Given this list of marker genes GPR65, IL18, VNN1, SMAD3, CD72, ERBIN, CD7, TMEM126A, SHLD2, NFKB1, SCIMP, HAVCR1, LSM14A, CCL28, FCGR2B, ARID1B, MIR708, GAB2, NOS2, IL10, TRPV4, TP53BP1, CX3CR1, MAP3K7, KLK3, DLL1, HSPA1A, SLC19A1, CD2AP, ZDHHC4, ATAD5 (NCBI Gene Id 79915), MARK4, BRPF3, RBP4, PRKCZ, HTR2A, CNOT7, TRIM62, GPS2, C8B, CCL4, PARP1, LOX, CYP26B1 (cytochrome P450 family 26 subfamily B member 1), IGLC3, ZBTB17, GPR18, INPP5D, PTPN2, VAMP7, HLA-C, CLEC12A, ZBTB26, MIR181C, APOA1, CTLA4, YPEL4, PYHIN1, LYAR, TBK1, ILDR2, TBC1D10C, APP, POMC, CD81, LIPA, HK1, CST7, IGHM, IL27RA, PAK2, GATA1, LETMD1, FCGR2A, GGT2P, IL13, CDKN1A, GRN, SOCS1, SOS1, PRDX2, IGHA2, MCU, CRTAM, MIR486-1, NR1H4, RBM14, COLEC10, CCL25, SH3RF1, PTK2, SMPDL3A, RAET1G, PIK3CA, TASL, CD226, CSF1, PIK3R1, HSF1, HCK, GAL, TRIL, KCNJ8, CEP63, METTL3, TRIM5, VTCN1, CCL1, GPX1, TNFAIP8L2, PTPN11 (protein tyrosine phosphatase non-receptor type 11), H4C1, BGLAP (bone gamma-carboxyglutamate protein), DLG5, INAVA, WNK1, IFNK, SPHK2, NFAM1, CD244, HOXB8, ENTPD7, FES, LEP (leptin), DDRGK1, MAPK3, CD1E, PLCB1, MFHAS1, HEXIM1, RIN3, PLA2G2A, PLA2G2D, RPS19, LEO1, CD2, HLA-DRB5, VSIR, PYCARD, GKN2, ING5, XBP1, IL6, CEBPB, NPLOC4, MAPK9, MAD1L1, PLA2G7, HLA-A, KIR3DL3, IFNL4, ZBTB25, HLA-DOB, XG (Xg glycoprotein (Xg blood group)), FLT3LG, FGL1, LAT, SIT1, GPR137B, CD300LB, BLNK, LAMP2, STK39, MPL, EFNB3, LIMK1, PRXL2A, ABHD8, BCL6B, THBS1, MSN, WAS, TLR10, PLCL2, TACR1, GP6, SELENOS, IL1A, KIR2DL5A, IFIH1, POLR3D, MEFV, RUNX3, LILRA3, GPR171 (NCBI Gene Id 29909), ACTL6B, EVI2B, ADCY7, CD3D, IFNA2, PLA2G4A, NLRC5, ADORA1, NCKAP1L, MBL2, TRAF3IP3, NEDD9, PMS2, ZDHHC5, PBRM1, C2, GLMN, C1R, ZDHHC9, IL15RA, LILRA2, LAPTM5, ANO6, EVPL, SH3KBP1, SQSTM1, NLRC3, PF4, CD79A, IL1B (interleukin 1 beta), IL17D, LITAF, CD96, CFHR4, TNFSF18, CD28, SMARCA4, CCR7, RC3H2, FBXW7, ULBP1, HLA-DQA1, HMOX1, ATAT1, INHBA, FGF10, EIF2B5, TOB2, XIAP, PJA2, FYB2, C5AR2, IKZF3, TNFSF4, PCBP2, CBLB, HHLA2, NOD2, IGHA1 (NCBI Gene Id 3493), POLR3C (NCBI Gene Id 10623), IL12RB1, ADA, PARP9, OGT, C8A, CD3E, CSF1R, C6, PDE4B, EBI3, TRBC2, BTN3A1, SIRPA, KLRC2, SCIN, IL18R1, BTNL10P, TAL1, CASP6, IL34, UBE2N, BCL2, FYB1, RNF39, TLR6, ZP3, BTN1A1, SASH3, LST1, PCK1, LAIR1, MIR221, BRD7, EPHB2, GPR137, SOS2, RIPOR2, MR1, KMT5B, ORM1, ELP6, OXSR1, IRAK3, TRIM25 (NCBI Gene Id 7706), KAT6A, HOXA9, MNDA, BTK, ERMAP, ZAP70, CEACAM20, BTN2A2, ZBTB6, TNFRSF11A, KLF13, TNFSF8, NLRP1, TRIM27, ADORA2B, TAFA3, CLU, TCIM, NFKBIL1 (NFKB inhibitor like 1), BCL6, IL23R, LAMP1, MIR17, TESPA1, ACP5 (acid phosphatase 5, tartrate resistant), TMEM176B, BTN2A1, NLRP6, EXOSC3, IL2, OTUD5, ATG9A, ACIN1, SOD1, LAT2 (linker for activation of T cells family member 2), CARD10, BTN3A3, SHH, MEF2C, COLEC12, FGL2, IL4R, TRPM4, PKN1, SYK, SLC7A5, PTGER4, SERPINB9, PIK3R6, MYC, FGR, TGFB2, RNF41, BTN2A3P, CNOT4, CXCL17, EPX, HLA-DPB1, ITGAM, CD99L2, MED23, TLR5, WNT3A, APLF, HSPA9, ZNRF4, LATS2, IL23A, CD1A, FCGR3B (Fc gamma receptor IIIb), PHPT1, ZBTB2, FURIN, XCL1, RASAL3, MED1, RAB29, SLC15A3, FPR1, SELENOK, MICA, RSAD2, HSP90B1, TREM2, PLD2, SLC22A13, AKIRIN2, H4C12, BTN3A2, RNF125, IL15, YWHAG, CD36, TMEM102, ST3GAL4, GPER1, WNT5A, MIR125A, FOXO3, CREBBP, IL36B, IGLC7, SLIT2, IFNB1, CR1L, LILRA1, LILRA5, DLG1, PIP, IFNL3, ZNF131, HMCES, UBASH3A, GDI1, GPR55, PTN, FOXF1, HAVCR2, HAX1, SPNS2, LGALS9C, LBP, CXCL12, LILRA6, CD59, KLRC4-KLRK1 (KLRC4-KLRK1 readthrough), H4C4, INHA (NCBI Gene Id 3623), FCGR3A, CTR9 (NCBI Gene Id 9646), ZBTB7B (NCBI Gene Id 51043), IL1R1, ANGPT1, PLAGL1, BCL10, BIRC2, DRD2, FCGR1BP, DNAJA3, MIA3, BANF1, DDX60, HLA-H, NFKBIA, TLR2, ECM1, C4BPA, DDX3X, TNFRSF4, IL7 (interleukin 7), TREML4, FSTL3, GPATCH3, ANXA1, PTPRJ, DPP4, REG3G, CDC37, CRKL, MAPK8 (mitogen-activated protein kinase 8), CD33, ZBTB46, BDKRB1, HLA-G, PUM1, TRIM6, HLA-DQA2, ULBP2, TNFAIP3, RHBDD3, HLA-B, CLEC6A, CIB1, CXCL6, KIR3DL2, MAD2L2, VSTM1, TNF, STAT3, CD84, JAM2, SDC4, RPS3, CSF3R, MYO18A, C5, CADM1, SHB, KLRB1, SMARCB1, MIR27A, TWSG1, CD300H, RPTOR, CD300A, FCN1, IKBKE, SERPINB4, ADIPOQ, SMARCD3, PRAM1, ANKRD17, CCR1, YTHDF3, CD177, NR1D1, PRELID1, ZBTB37, PVRIG, H4C11, TEC (tec protein tyrosine kinase), MIR30B, ZDHHC3, SCRIB, DUSP3, GPR15LG, BAD, MIR520E, DCSTAMP, HLA-DRA, TRIM41, SERPING1, LRRC32, FAM3A, CD38, MUL1, DEFB131A, PGF, FOSL2, PLCG1, ADGRE2, FLOT2, PLCG2, IL6R, RFTN1, TRAF6, CD300LD, DHX58, RPS6KA3, C3, ZBTB14, C4BPB, SOX12, SPON2, ATG12, SH2D1A, RAC2, FUT9, DUSP1 (dual specificity phosphatase 1), GATA3, CARTPT, FFAR2, RASSF2, TAX1BP1, HLA-F, MAPK10, ZMIZ1, SLA2, SHPK, CHST2, SRC, MAPK11, CD46, SMAP1, CTSS (NCBI Gene Id 50653), BMP5, PRNP, ACVR2A, AP1G1, KCNK6, MIR6869, CXCL13, FOXN1, P4HTM, TGFBR2, H4C5, COL3A1, STAP1 (signal transducing adaptor family member 1), CSNK1A1, KITLG, NOTCH2, CCL19 (C-C motif chemokine ligand 19), MITF, CCDC134, ACOD1, PLPP4, SPN, KRT1, LRRC14, CHUK, FOXP3, CD14, RASGRP1, IL7R, ABL2, LILRB1, SELP, PRG2, JAM3 (NCBI Gene Id 84887), GABPA, TLR3, USP5, ALPK1, EIF2B2, PDE4D, ZP4, TNFRSF1B, CALR, GBP1, SLC46A2, NEK7, CCN3, RBCK1, APOA2, RNF34, LTA, SIRPB1, BLOC1S3, CSF3, RNF115 (NCBI Gene Id 27246), CEACAM7, MAFB, HCST, NLRX1, TCTA, CREB3, BRD2, NCF1, ADORA2A, SFRP1, ZNF16, PSMA1, PRKAA1, STOML2, PDPK1, POU4F2, BAG6, RAG1, MERTK, CHST4, CLC, CCR2, SMARCD2, GRB2, MASP2, ZFP36L1, AHR, WDFY1, NLRP2B (NCBI Gene Id 286430), HOXA5, CD1B, MAPKAPK3, PRDM16, CD3G, BST2, ZCCHC3, SKAP1, ZBTB20, GGT1, NCR3, MIR24-1, MAP3K1, FCN3, CUL4A, TIFAB, NLRC4, LGALS9B, ATM, CFH, HIF1A, SLC7A11, MAP2K4, SNX4, CD99, ESR1, USP17L2, CLPB, VAMP8, GATA2, CRK, SOX11, ARNT, GGT3P, INS, FN1, FZD5, EFNB1, TAPBPL, TNFRSF13B, PIK3CD, NLRP10, CACNB3, IDO1, CD24, CTNNB1, UBASH3B, YTHDF1, MAP2K7, DUSP10, CD5L, TLR4, SLAMF6, IAPP, PLA2G1B, PATZ1, CFHR3, MMP8, KIR2DS4, SH2B2 (SH2B adaptor protein 2), BPIFB1 (BPI fold containing family B member 1), TNFRSF9, BTNL3, RIF1, YTHDF2, DHX9, THY1, FCGR2C, IL2RG, APPL2, FAM76B (family with sequence similarity 76 member B), MALT1, IGFBP2, NCK1, RAET1E, CD200R1, AMBP, PLA2G10, TMBIM6, PTPN6, ZBTB39, HCFC2, MAP2K6, SPHK1, CD6, SLC4A2, SIRT1, NLRP4, APCS, NAIP, NPY, SMPD3, MSH2, H4C13, TCF3, FADD, LDB1, HLA-DRB4, PRKD1, IGHD, USP15, SIVA1, LRCH1, PTK2B, SOX4, CD300E, SOX13, DOCK8, CLCF1, ITGA2, PTPRD, LGALS8, PHLPP1, P2RY12, PTPRC, VSIG4, STX4, LACC1, CASP3, CMTM3, STAT5B, LAIR2, NFKBIZ, ZBTB34, TNIP1, AARS2, FPR3, TNFSF9, CD47, KAT2A, AP3B1, L3MBTL1, TMIGD2, ZNRF1 (zinc and ring finger 1), DAPL1, POLR3G, NFKBID, PIBF1, VEGFD, TREX1, HLA-DRB3, LTF, KCNK18, CFHR5 (complement factor H related 5), WASHC4, FOSL1, PPP3CB, MAP3K8, PPP3CA, SWAP70, ZNF572, SIGLEC15, ITGB3, N4BP1, PRLR, GPAM, LIME1, CARD11, SOCS5, ARID5A, RAP1A, THEMIS2, EDN2, ZBTB16, MIR520B, MEAF6, ETS1, MIR128-1, STXBP2, LCP2, JAG1, GPNMB, TYK2, RPL13A, GFI1, CGAS, MEIS2, GPRC5B, RABGEF1, HMGB1, HCLS1, CD209, GPI, ZBTB45, DHX33, CD200, IGHG1, PRKCD, C3AR1, PLA2G3, NRARP, PRKCH (protein kinase C eta), KAT6B, MIR146A, PLSCR1, TRGC2, PTPN22 (protein tyrosine phosphatase non-receptor type 22), PRKD2, KLK5, TLR1, PKP3, BRPF1, FCGR1A, GDF15, BMI1, ELANE, ACTL6A, CCL21, PPP2R3C, KLF10, TAP2, BRD4 (bromodomain containing 4), ANKRD54, IL20RB, TBX21, CACTIN, RELA, PAXIP1, LRRC19, TKFC, ARG1, SENP1, CLECL1P, PHB2, CCDC88B, TRIM3, TAOK3, KLK7, LGR4, MAPK1, EPG5, MIR125B1, AKIRIN1, ZFPM1, SMIM30, ZDHHC1, IL4I1, SLC15A4, TSPAN32, LAX1, YWHAZ, IGLC1, PUM2, BTNL2, PARK7 (Parkinsonism associated deglycase), DAB2IP, MAPKAPK2, CAV1, LRRK2, NAGK, MIF, IGF2, KIR2DS3, GPR33, EIF4E2, CUEDC2, IRF1, SMARCD1, KIR2DS2, KIR3DL1, PIK3AP1, OAS1, PTPN1, ZBTB33, TRAF2, FOXJ1, TRIM21, FANCA, DDX1, PIK3CB, IGF1, FPR2, ELF1, CPT1A, MARCHF7, CORO1A, GBP5, RIPK3, CLNK, IRF4, MIR223, SMARCC1, IL20, SYT11, HLX, CD5, CACNB4, CFD, CCL2, CD37, HLA-E, SPTA1, EREG, ICOS, JAK3, STAT1, ZNF675, ERFE, WASL, CD8B, IRAK4, CD1C, IL33 (interleukin 33), ASCL2, AZGP1, GALNT2, TLR9, MIR302A, KAT7, PARP3, ZC3H12A, BID, HSPA8, CDKN2A, RNF31, NOP53, DENND1B, HES1, CNN2, SNCA, NKAP, HMGB3, ABL1, SCARA3, RHOH, AP3D1, AXL, CALHM6, PTPRE, ITPRIPL1, OTULIN, CYBA, TESC, HLA-DQB2 (NCBI Gene Id 3120), MIR210, ACTB, MPP1, FCHO1, SNAI2, ZC3H8, PRKDC, RBM47, MIR200B, STMP1, SHLD3, JUNB, CD8B2, NFE2L2, TXK, GPSM3, TNFAIP6, TNFSF14, GREM1, JUND, NDFIP1 (NCBI Gene Id 80762), TRIM56 (NCBI Gene Id 81844), MZB1, SFN, STXBP1, ZBTB49, IL4, MEIS1, NLRP3, TRAFD1, TAB1, THBS4, CR1 (complement C3b/C4b receptor 1 (Knops blood group)), ZBTB32, C9, ITGA2B, CFB, KIR3DX1, MIR18A, TGFB1, C17orf99, RIPK1, SMCR8, KIR2DL5B, SMARCC2, SFPQ (NCBI Gene Id 6421), EGR3, ORM2, LILRB3, SIRPG, EIF6, LGALS3, CSK, PGLYRP3, PGC, DNASE1, MIR105-1, TNFSF11, DDX21, S100A8, IGHG4, C1RL, P2RX4 (NCBI Gene Id 5025), PSMB4, PAF1, PHB1 (prohibitin 1), ADGRF5, HLA-DRB1, TSLP, CD1D, PSEN1, MS4A1, UBE2K, HIC2, GAS6, PHF10 (PHD finger protein 10), SEMA7A, UBE2J1, POLR3B, WDR41, GATA6, MIR302E, GPR32P1, RNF170, PRKCQ, KLHL25, CFHR2, NPY5R, EFNB2, IL17F, TRBC1, TRIM11, CAMK4, CD79B, CALHM2, TRDC, SART1, CYLD (NCBI Gene Id 8010), GIGYF2, HLA-DMA, MIR181B1, ZFP36L2, HSPD1, MICB, TRAT1, PTPRS, LILRB2, TNFRSF13C, PRKAR1A, EIF2B1, PQBP1, TCF7, ARG2, CARD8, PRKCA (protein kinase C alpha), CLEC4D, HSPH1 (heat shock protein family H (Hsp110) member 1, NCBI Gene Id 9835), PYDC2, RASGRP4, PAWR, LGALS1, RAC1, PLK2, LYVE1, FCRLB, F2RL1, EIF2AK2, IGLC6, H4C8, GPLD1, KIR2DL4, RARRES2, IFI16, TRIM32, ITK, FKBP1A, SOCS6, ZNF580, RTN4, TNFRSF11B, BPI, BTNL9, KAT5, ZNF335, GFI1B, PLVAP, H4C3, TMEM178A, ADAM17, TNFSF13B, GLI3, CASP1, MYB (MYB proto-oncogene, transcription factor), TRIB1, CD40, RNF185, H4C14 (H4 clustered histone 14), CEACAM1, MCUB, MAPK8IP1, LILRA4, GLUL, DDX39A (NCBI Gene Id 95781), SECTM1, KIT, MIR142, FSHR (NCBI Gene Id 4959), PLA2G2F, DHPS, AIF1, BMP4, PYDC5 (pyrin domain containing 5), TRAC, GPR151 (NCBI Gene Id 134391), IKBKB, VEGFA (NCBI Gene Id 7422), STK10, CD276, RUNX1, TICAM2, NR4A3, IL13RA1 (interleukin 13 receptor subunit alpha 1), F7, IRF5, CRLF2, LYN, ZDHHC18, FERRY3, BLK, CD86, SPG21, ZFP36, ZNF683, LDLR, MICOS10-NBL1, CD83, TMEM131L, TIRAP, KLHL6, P4HB, HDAC6, SMAD7, LIF, CD320, FUT7, TRAF3, NONO, PRKCE, PIM1, SPINK5, MTURN, MMP12, RIGI, CLDN18, IL18RAP, BLOC1S6, IGSF1, C7, PAK3, H4C6, LMO1, VEGFB, SUSD4, AKT1, CD9, RAB11FIP2, CCL24, BRD1, UBR2, LOXL3, PVR, ATG5, SERPINE1, KCNN4, MYSM1, TIGIT, IGHG2, MIR21, COLEC11, INPPL1, BANK1, SPSB3 (NCBI Gene Id 90864), RARA, BCR, TMEM176A, DDX41, FAM3D, ZEB1, CCR6, SIN3A (NCBI Gene Id 25942), JAK2, BATF, PGLYRP1, CLEC7A, FYN, PPARGC1B, C1QA, BIRC3, NINJ1, CTSC, KIR3DS1, P2RX7, MMP28, IFNL1, STAT5A, FCMR, KLRC1, CALCA, CEBPA, IL31RA, MIR222, H4C9, MIR34A, EMILIN1, CD4, OTUD4, PANX1, POLR3F, S100A9, GPR17 (NCBI Gene Id 91962), DNAJB9, CASP8, TRGC1, CD247, PLA2G6, CTSH, C1QB, IRAK1, OAS3, IRF3, GCSAML, FBN1, DGKZ, MIR185, EDN3, LAG3, IL21, STAT2 (NCBI Gene Id 6773), CD55, MIR149, CR2, PERP, LILRB4, PLPP6, PPP2CA, PSPC1, C4A, SLC11A1, DEFB124, RHOA, TYRO3, CCL8, TYROBP, CXCR3, KLRK1, NFATC2, GPR183, DROSHA (drosha ribonuclease III), SMPDL3B, MKRN2, FOS, SLC8B1, SLC7A1, C1QBP, C1S, STING1, STAT6, UFD1, FOXP1, CDK6, MOG (NCBI Gene Id 4340), TTBK1 (tau tubulin kinase 1, NCBI Gene Id 84630), GPR32, POU4F1, GNRH1, CYRIB, CD27, AIRE, OLFM4, NBL1, UBQLN1, ISG15, PPP6C (protein phosphatase 6 catalytic subunit), CD300C, IL1RL2, CTSG, IL12A (interleukin 12A), HFE, CD68, VAV1, BTLA, SHLD1, RNF135, MIR130A, TWIST1, DDT, TOMM70, ERAP1, UNC13D, CNR2, PRKCB, MAPK14, LYPLAL1, CBFB, NMI, BECN1, HLA-DQB1 (NCBI Gene Id 7924), IGHE, LPXN, NAGLU, UNC93B1, CX3CL1, PNP, NECTIN2 (NCBI Gene Id 5819), ADTRP, USP29, SLC39A6, TNIP2, IKBKG, THEMIS, ECSIT, RB1, ARID2, OASL, PIGR, BTNL8, TFRC, PAK1, LY96, ITPKB, KIR2DL3, SPPL2B, TNFRSF18, SCGB1A1, NR1H2, TSC22D3, LRCH4, KLHL22, HLA-DMB, GNAS, ITGB2, OSCAR, MARCHF5, UFL1, FFAR3, DCAF15, CFP, FCAR, XRCC6, GPR31, ENPP3, TFE3, HSPA1B, USP50, KLRD1, CAMK1D, SUPT6H, CXCL10, S100A7, KIR2DL1, TGFB3, AIM2, TARM1, CCL7, SPI1, DHX36, NR5A2, SELE, CARD14, ZBP1, TLR7, FCN2, PURB (purine rich element binding protein B), DCST1, TRIM15, CREB1, RAG2, PCID2, TNFRSF14, HPX, ALOX15, SPPL2A, PELI1, GBP2, ACVR1B, ARID1A, CCL3, IL5 (interleukin 5), APOE (apolipoprotein E), SIAE, PARP14 (poly(ADP-ribose) polymerase family member 14), KLRC4, TTLL12, MILR1 (NCBI Gene Id 284021), CDC73, C5AR1, PLA2G5, IFNL2, MIR145, FLOT1, ZBTB12, ABCB10, GPR68, HRAS, PDCD1LG2, ID2, GLI2, TNFRSF21, NR1H3, ZC3HAV1, EPO, PPT1, CFI, DAPK2, LEF1, MASP1, IL2RA, CLPTM1, SKIC8, XRCC5, ARRB2, LRRC17, RIPK2, HLA-DPA1, CD40LG, STK11, USP18, LCK, SH2D1B, FBXO38, FUT4, BCAR1, CPTP, AURKB, LRFN5, MTUS1, CEACAM3, DTX4, VAV3, TRIM31, SEC14L1, IRF7, KIR2DS1, HMSD, C9orf72, THPO, TRIM65, MYO1G, DUSP22, CD19, HSP90AA1, ZBTB1 (zinc finger and BTB domain containing 1), IRGM, KCNK13 (NCBI Gene Id 56659), RGCC, H4C15, NCK2, SLAMF1, VEGFC, PSG9, SLC9B2, CLEC4G, FCER1A, EZR, NECTIN4, CARD9, YES1, MAVS, SARM1, NCR1, CD8A, DTX1, MIR19B1, TSPAN6, CMKLR1, C4B, ITCH, STX7, PDCD1, IL6ST, ZNF134, TM4SF19, PLEKHA1, ZNHIT1, TLR8, PIANP, TMIGD3, YWHAE, GCNT1, RAET1L, SLAMF8, CTNNBIP1, MIR17HG, KARS1, HLA-DOA (NCBI Gene Id 51034), MMP14, VCAM1, RHBDF2, NSD2, SLC15A2, CFHR1, SMARCE1, GPR108, KHDRBS1, CYP19A1, A1BG, VAMP3, ZPBP2, MIR136, AMBRA1, MIR19A, H4C2, HRG, PRMT6, LATS1, ICAM1, VAV2, TNIP3, RAC3, LGALS9, FANCD2, BST1, SPACA3, HMGB2, SLC39A10, MIR200C, CCL20, PITHD1, USP27X (NCBI Gene Id 389856), TNFSF13, PDGFD, OCSTAMP, CD160, SAMSN1, EEIG1, PIAS3, RASSF5, IGHG3 (immunoglobulin heavy constant gamma 3 (G3m marker)), FER, ITGA4, IL17A, ULBP3, CLEC4E, KLRC3, BRCC3, MIR20A, PRMT1, IL12B, ADAR, ZNFX1, CHRNB2, ERBB2, CCL5, CD70, LGMN, FBXL2, RORA, SOX9, GCSAM, FCER2, IFNG, WNT10B, CD300LF, PAG1, TIFA, CD101 (CD101 molecule), IL13RA2, BRAF, CD74, MLH1, ABHD17A, EIF2AK4, IRS2, PYDC1, CEACAM4, MADCAM1, MTOR, PPARG, C8G, EP300, EIF2B3, MATR3, SFTPD, MDK, IL16, EIF2B4, RC3H1, OTOP1, SMARCA2, USP38, MIR140, SIRT2, ICOSLG, APOD, IL27, TICAM1, MIR4691, TOX, C1QC, TARBP2, FSHB, FBXO7, PRDM1 (NCBI Gene Id 639), MSTN, PADI2, OPA1, B2M, PGLYRP2, CD80, DNM1L, SAMHD1, DNASE1L3, FAXDC2, AGER, HOXA7, IHH, CLEC12B, APPL1, KMT5C, FCRL3, IFI35, ZDHHC12, IGKC (NCBI Gene Id 3514, immunoglobulin kappa constant), FAM210B, MOSPD2, RBM15, TAC1, DNASE2, EDN1, RARG, CD22, GSDME, ADAM8, CD69, RAB7B, TMEM64, BAX, NF1, EXOSC6, KIR2DL2, BMX, FCER1G, GRAMD4 (NCBI Gene Id 23151), RCOR1, S100A14, RIOK3, TSC22D1, KIR2DS5, ADAM10, RNF144A, MYD88, BTRC, NOD1, LRP8, A2M, RHEX, IL1RL1, AQP3, HCAR2 (NCBI Gene Id 338442), QKI, CD274, H4C16, CXCL8, IRAK2, IPO5, SPPL3, LILRB5, here is a description of the gene set: species: Homo sapiens Human Gene Set: GOBP_REGULATION_OF_IMMUNE_SYSTEM_PROCESS Any process that modulates the frequency, rate, or extent of an immune system process.